Given this list of marker genes SERPINA9, CTAG2, RAP1GAP2, YPEL3, TMPRSS7, CYTL1, CFAP184, PLPP4, KAZALD1, KRT4, BAHD1, PCSK6, MYC, ETS1, ZC3H10, CYTIP, EPO, PTPRC, TOM1 (target of myb1 membrane trafficking protein), PTGER2, PREB, TYW3, LYPD2, HEYL, GIMAP3P, KCTD11, KCNMA1, COBLL1, NKX6-3, FOLH1, HLCS, SLC47A2, NPR2, PSAP, LIMA1, LDB1, SLC27A2, HEXD, MMRN2, BTNL2, CYYR1, INPP5K, NEU3, MRO, GNB1L, GARIN1A, PRR15, ACAA2, RANBP9, FAIM2 (Fas apoptotic inhibitory molecule 2), KRT26, ACTG2, CARD11, IRF9, UBE2L3, CPEB1, NMRK2, DGAT1, ECM1, ARHGDIB, MYH7, ADAM2, DHRS7C, JDP2, WLS, MIR155, TXNIP, NLRC5, RADIL, LARGE2, IL2RB, GBP2, TRIM65, FNDC8, ATP6V0E2, CDK9, SEPTIN12, LRRC19, TRIM26, SHC4, SLC16A2, CACNB3, FMN1, ELL (NCBI Gene Id 84205), DPPA3, PROZ, ACKR3, TCTN3, NPC1L1, SMAGP, INHBA, MAST1, SLC46A2, DAZAP1, GPR146, DGKA, LYG2, RAD51D, LRRC38, CASP8, KLF4, SYCE1 (synaptonemal complex central element protein 1), PIM1, GAL, ABLIM1, ARL4D, UFSP1, NINL, LCT, PROP1, SH3BP4, CFAP144P1, AMBP, PLCXD2, SLC4A1, INMT, MED29, IGF2, MGAT5, PLIN2, GNA12, FXN, PLK2, GJC2, BSX, EFCAB3, GRAP2, CAPN8, JAKMIP3, TMEM39B, DPEP2, MYL11, SYNM, DUSP23, SYT10 (NCBI Gene Id 341359), RAB27B, here is a description of the gene set: species: Homo sapiens During acute viral infections, effector CD8+ T cells differentiate into memory precursors or short-lived terminal effectors. miR-17-92a over-expression skews CD8+ effector cells to the terminal differentiation. We used microarray to identify the genes that are differentially expressed caused by miR-17-92a over-expression. Human Gene Set: GSE34217_MIR17_92_OVEREXPRESS_VS_WT_ACT_CD8_TCELL_UP from publication Wu T, Wieland A, Araki K, Davis CW, Ye L, Hale JS, Ahmed R (PMID 22665768) Genes up-regulated in act CD8 T cells: over-expressing MIR17HG versus activated control.